The following is a description of a gene set: Human Gene Set: GSE42724_NAIVE_BCELL_VS_PLASMABLAST_UP Genes up-regulated in B lymphocytes: naïve versus plasmablasts. studied in species Homo sapiens The recent discovery of the human B1 cells, identified by the expression of CD20, CD27 and CD43 in absence of expression of CD70 and CD69 has been subject of debate. Some studies have raised the possibility that these cells are B cells differentiating towards the plasmablast and plasma cell stage rather than being the human counterpart of murine B1 cells. No further in depth studies have been performed. Therefore, a functional comparison was made between, the proposed B1 cells and plasmablasts. We observed that for several functional characteristics (distribution of isotypes of spontaneously producted antibodies, production of antigen-specific antibodies after vaccination with both T-cell dependent as well as T-cell independent antigen, the proposed B1 cells behaved similar to plasmablasts. In addition, we were able to differentiate the proposed B1 cells in vitro, indicating that they are not from a distinct lineage as the murine B1 cells. Gene expression analysis revealed that these cells cluster between memory B cells and plasmablasts, contradicting them being the genuine human counterpart of murine B1 cells, rather revealing a preplasmablast phenotype. from publication Covens K, Verbinnen B, Geukens N, Meyts I, Schuit F, Van Lommel L, Jacquemin M, Bossuyt X (PMID 23613519), and this is the list of marker genes: FBXO32, PARP12, TYMP, PHACTR4, OASL, NRIP1, RAB8A, VSIG10L, LAP3, ZNF107, C4orf33, PNPT1, DACT2, ISG20, DDIT3, MOV10, KCTD14, B3GNT2, PSME1, UBA7, EIF2AK2, SIGLEC1, BST2, FUT4, OAS2, DDHD1, CD38, PCGF5, EPHB2, DDX60L, RIGI, DNAJB4, CXCL11, FCHSD1, IFIT2, USP18, CARD16, TAPBPL, CFB, TMEM140, SWT1 (SWT1 RNA endoribonuclease homolog), ISG15, CNP, MAD2L1BP, MX2, GBP4, IRF9, SP140, MIA3, E2F8, TNFSF10 (NCBI Gene Id 8743), IFITM1, MX1, XAF1, TRIM21, HLA-F, HERC5, TAP1, SAMD4A, TENT5A, RTN1, PARP10, AXL, GBP5, EPSTI1, TLR3, FILNC1, GBP1, SAMD9, SHISA5, STOM, HERC6, RBM11, TDRD7, SERPING1, IRF1, STARD4, BRIP1, TRAFD1, NKIRAS2, MASTL, IFIH1, GMPR, RSAD2, ITIH4, RAD9A, IFI27 (interferon alpha inducible protein 27), PATL1, IRF7, ZNFX1, DESI1, ST7, BATF2, PML, HELZ2, H2AC6, STAT1, TMEM268, FBXO6, MRPL40, CXCL10 (C-X-C motif chemokine ligand 10), KIRREL1 (kirre like nephrin family adhesion molecule 1), GCLM, IFI44L (NCBI Gene Id 10964), NLRC5, ZBP1, MVP, STAT2, LAG3, UBE2L6, TRIM25, LY6E, LGALS3BP, APOL6 (apolipoprotein L6), SQSTM1, APOBEC3A, RTP1, UBAP1, CLEC1A, IFIT3, CD2AP, USP30-AS1, NEXN, HSH2D, C15orf48, TAP2, SLC25A28 (solute carrier family 25 member 28), PSMB9, SSB, HESX1, IL15RA, SRGAP2 (NCBI Gene Id 440748), PLSCR1, DNAJB9, SAMD9L, NUB1, SPATS2L, FRMD3, SCARB2, OAS1, OTOF, TRIM5, OAS3, MCM5, RTP4, IFI44, PSMA4, PRR9, COQ10B, APOL1, TAF5LP1, DTX3L, BTG3, SHFL, TESMIN, TIMD4, ARPIN, HUS1, CLDN1, PPM1K, ACSM5, SLC22A4, TREX1, CMPK2, CLEC4D, CASP12, MYD88, CASP1, IFIT1, PARP9, EPDR1, NMI, NADK, IFI35, AIM2, TYW5, TRIM22, TUFT1, PARP14, CMTR1, DHX58, CARINH, GCH1, NAPA, ITGB7, NT5C3A, CSRNP1, DDX60, PDGFRL, RIPK1, CHRM1, FAM234B, SP110, PPP4R3C, XPO6, PLAAT4